The following is a description of a gene set: Reactome Pathway: Response of endothelial cells to shear stress Vascular endothelial cells experience shear stress produced by the flow of blood across their apical surfaces. Different types of shear stress have been identified based on the type of flow and the response of the endothelial cells: low volume laminar flow, high volume laminar flow, and turbulent (disturbed, oscillatory) flow. A key difference between the responses of cells to the different types of flow is the absence or presence of inflammation. Whereas high volume laminar flow produces vasodilation and cytoskeletally based streamlining without inflammation, both turbulent flow and low volume laminar flow activate the inflammatory NF-kB and YAP1 pathways.<br>All types of flow activate the mechanosensitive cation channel PIEZO1, resulting in an influx of calcium ions. Calcium binds and activates the Calpain2 protease complex which acts on cytoskeletal proteins near the inner face of the plasma membrane, causing alterations to the morphology of the cell. In the case of high volume laminar flow, cells become ellipsoid with their long axes parallel with the flow of blood.<br>In addition to optimization of cell shape, high volume laminar flow activates AKT1 via ligand-independent KDR (VEGFR2) signaling, ATP-dependent P2RY2 signaling, and Adrenomedullin (ADM) signaling. AKT1 and other kinases then phosphorylate NOS3 (eNOS), resulting in increased production of nitric oxide and vasodilation. High volume laminar flow is thus atheroprotective.<br>In contrast, turbulent flow activates signaling by integrin alpha5:beta1 (ITGA5:ITGB1) that causes the phosphodiesterase PDE4D5 to hydrolyze cAMP and the phosphatase PP2A to dephosphorylate and hence activate the transcription factor YAP1. YAP1 positively regulates expression of pro-inflammatory genes. Also during turbulent flow, Focal adhesion kinase (PTK2, FAK) is activated by phosphorylation and causes phosphorylation and nuclear translocation of the pro-inflammatory transcription factor complex NF-kB. part of: Cellular responses to mechanical stimuli studied in species Homo sapiens, and this is the list of marker genes: GNB1, MTOR (NCBI Gene Id 2476), IKBKB, GNB4, MAPKAP1, NFKBIA, GNB5, GNA11 (NCBI Gene Id 93626), PECAM1 (NCBI Gene Id 5175), PRKAR2B, GNG3, ADCY5, ADCY9, PKN2, GNGT2, ADM, IKBKG, FN1, PANX1, CALM1, IKBKE, RICTOR, CAPNS2, PPP2R1A (NCBI Gene Id 5518), ADCY2, CAPNS1, PTK2, ADCY4, PIK3R2, PIEZO1, ITGA5, PRR5, PPP2R1B, GNG13, MMP14, PPP2CA, YAP1, PRKACG, GNG8, GNG11, PDPK1, GNG4, GNG7, ABL1, CALCRL, ADCY8, TLN1, PRKACB, GNAQ (NCBI Gene Id 2776), PRKAR1B, PRKACA, ADCY3, TRPV4, PIK3CB, GNG10, CTNNB1, NFKB1, CHUK, ADCY6, PDE4D, AKT1, PPP2R2A, NLRP3, PRKAR1A, KDR, GNAS, PIK3CA, ITGB3, CDH5, P2RY2, GNB2, ADCY1, RELA, GNB3, STAT1, ITGAV (integrin subunit alpha V), FLT4, GNG2, RAMP2, ITGB1, FYN, PRKAR2A, VCL, GNG12, ANXA2, PIK3CD, GNG5, MLST8, PTPN1 (protein tyrosine phosphatase non-receptor type 1), NOS3, GNGT1, ADCY7, CAPN2